Given this list of marker genes IRS2, RN7SL141P, FAM131B-AS2, CTSK, ALOX15B, CPXM1, RGCC, ZNF416, IL1RL1, IGFBP6, LINP1, MAP3K4-AS1, TCEAL3, CD248, FAM89A, ATP13A3, IGSF10, PIP5K1C, LINC02916, POLD4, PGR, STARD5, HSD11B1, ASIC3, CNR1, SCARA5, CD82, TIMP1, GPBAR1, ADAMTS1, TAS2R1, IFI35, PODNL1, FICD, THY1, A1BG-AS1, SPON2, ISLR, CRISPLD2, TGM2, NFE2L1, ADRA2C, HSPB6, LINC02432, ANGPTL5, SLC37A3, ULBP1, CCL24, APOD, MAPK7, SLC39A6, ING1, HAND2-AS1, CILP, PLAC9P1, LINC01270, MMP27, MOV10L1, SULF2, ADAMTS15, GREB1, P4HA3, LINC01204, PLPP1, GASK1A, PRL (prolactin), COL6A4P1, B2M, LINC00987, CATIP-AS1, HOXA11, MTND4LP1, ENSG00000253397, LRRN4CL (NCBI Gene Id 221091), S100A3, MIR4453HG, KIAA0040, GAS1, IL1R1-AS1, MMP19, SUMF2, MRPS6, ANKRD30B, OSR2, EMILIN2, PCYOX1, DEPP1, SPTSSA, MAOB, UBE2L6 (ubiquitin conjugating enzyme E2 L6), PCDHGB6, CARS1-AS1, VASN, OMD, POLR1F, SERPING1, CRYGN, MFAP4, LUM, OXTR, THY1-AS1, CHST7, ENPP1, SNX21, A2MP1, TEX26-AS1, TMEM45A, LTBP2, LGALS1, CHPF2, LINC02281, IGFBP4 (NCBI Gene Id 3487), LINC02600, PRLR, WNT5A (NCBI Gene Id 7474), GDF7, CFD, DEFB124, ATP2B4, MOSPD2, EPYC, TSKU, PAPOLB, SSC5D (NCBI Gene Id 284297), LMOD1, LINC00092, MIA2-AS1, DKK1, RRAS, PILRA, TMX3, TUBA3E, ACE, AOX1, MYO16-AS1, ABI3BP, OSGIN2, MYG1-AS1, MXRA8, COPZ2, SYN3, HTR2B, TCEAL4, PBXIP1, PROK1, TMEM37, MMP2, MACC1-AS1, APOL1, PLPP3, CYB561D2, APOO, AADACL4, CLEC2B, C1QTNF1, LEFTY2, CITED2, CHST2, RTL10, C17orf114, CHRDL1, PRR15, GBP1, PDLIM2, LINC02349, SH3RF3-AS1, DCN, TMEM198B, CHI3L2, NDP, DPYD-AS1, LRRC15, CAB39L, ADAMTS5, FOXL2, RNVU1-6, RBP1, PALMD, SPSB1, F2R, here is a description of the gene set: Human Gene Set: DESCARTES_MAIN_FETAL_IGFBP1_DKK1_POSITIVE_CELLS species: Homo sapiens The gene expression program underlying the specification of human cell types is of fundamental interest. The study authors generated human cell atlases of gene expression and chromatin accessibility in fetal tissues. For gene expression, the study authors applied three-level combinatorial indexing to >110 samples representing 15 organs, ultimately profiling ~4 million single cells. The study authors leveraged the literature and other atlases to identify and annotate hundreds of cell types and subtypes, both within and across tissues. Our analyses focused on organ-specific specializations of broadly distributed cell types (such as blood, endothelial, and epithelial), sites of fetal erythropoiesis (which notably included the adrenal gland), and integration with mouse developmental atlases (such as conserved specification of blood cells). These data represent a rich resource for the exploration of in vivo human gene expression in diverse tissues and cell types. Marker genes curated from the annotated cluster as represented in the Descartes Human Gene Expression During Development database. from publication Cao J, O'Day DR, Pliner HA, Kingsley PD, Deng M, Daza RM, Zager MA, Aldinger KA, Blecher-Gonen R, Zhang F, Spielmann M, Palis J, Doherty D, Steemers FJ, Glass IA, Trapnell C, Shendure J (PMID 33184181)